Given this list of marker genes TSHR, TNFRSF1B, HESX1, DGUOK, P4HTM, ACADVL, TSPYL1, TG, DBH, MT-ND6, ACADSB, LMNB1, TBCK, GABRA2, TSHB, HLA-DRB1, MT-ND1, MT-ND3, IVD, MT-ATP6, MT-TW, UQCRFS1, SCN11A, HMGCL, MT-ND4, CRELD1, SCN10A, NAGS, SLC25A20, OTC, MT-TV, MT-TL1, PAX8, SCN9A, LHX4, BRAT1, MT-ND2, PROP1, BTNL2, MICOS13, MT-TK, DUOX2, DDC, COA6, COQ9, SUCLG1, CD28, MT-ND5, LHX3, SLC5A5 (NCBI Gene Id 6528), ATP7A, IYD, SLC52A1, NTRK1, DUOXA2, MMACHC, CACNA1C, POU1F1, CTLA4, TPO, here is a description of the gene set: studied in species Homo sapiens Human Gene Set: HP_HYPOTHERMIA Hypothermia Reduced body temperature due to failed thermoregulation.